Given this list of marker genes Cth, Mthfd2l, Bhmt1b, Mri1, Mthfr, Enoph1, Ggt1, Mtrr, Mthfd1, Bhmt2, Apip, Mtr, Adi1, Cbs, Bhmt, Mtap, here is a description of the gene set: The chemical reactions and pathways resulting in the formation of amino acids containing sulfur, comprising cysteine, methionine and selenocysteine. Mouse Gene Set: GOBP_SULFUR_AMINO_ACID_BIOSYNTHETIC_PROCESS species: Mus musculus